Given this list of marker genes Tac1, Camp (NCBI Gene Id 12796), Ltf, Ang4, Ang2, Ang5, Npy, Rarres2, App, Il36rn (interleukin 36 receptor antagonist), Ang, Vip, Spag11a, Fam3a, Ang6, here is a description of the gene set: An immune response against a fungus mediated through a body fluid. An example of this process is the antifungal humoral response in Drosophila melanogaster. species: Mus musculus Mouse Gene Set: GOBP_ANTIFUNGAL_HUMORAL_RESPONSE